The following is a description of a gene set: studied in species Homo sapiens Human Gene Set: DESERT_PERIPORTAL_HEPATOCELLULAR_CARCINOMA_SUBCLASS_UP Genes up-regulated in the periportal-type subclass of hepatocellular carcinomas. Sets created as part of a metaanalysis of nine public transcriptomic datasets merged into a metadataset including 1133 human hepatocellular carcinomas obtained after curative resection. For platform descriptions of each one of the 9 datasets, see Figure 1B in Désert et al., Hepatology (2017), 66: 1502-1518. Hepatocellular carcinomas (HCCs) exhibit a diversity of molecular phenotypes, raising major challenges in clinical management. HCCs detected by surveillance programs at an early stage are candidates for potentially curative therapies (local ablation, resection or transplantation). In the long term, transplantation provides the lowest recurrence rates. Treatment allocation is based on tumor number, size, vascular invasion, performance status, functional liver reserve and on the prediction of early (< 2 years) recurrence, which reflects the intrinsic aggressiveness of the tumor. Well-differentiated, potentially low-aggressiveness tumors form the heterogeneous molecular class of non-proliferative HCCs, characterized by an approximate 50% beta-catenin (CTNNB1) mutation rate. To define the clinical, pathological, molecular features and the outcome of non-proliferative HCCs, we constructed an 1133-HCC transcriptomic metadata set and validated findings in a publically available 210-HCC RNAseq set. We show that non-proliferative HCCs preserve the zonation program that distributes metabolic functions along the porto-central axis in normal liver. More precisely, we identified two well-differentiated, non-proliferation subclasses, namely Periportal-type (wild-type CTNNB1) and Perivenous-type (mutant CTNNB1), which expressed negatively correlated gene networks. The new Periportal-type subclass represented 29% of all HCCs; expressed an HNF4A-driven gene network, which was down-regulated in mouse Hnf4a-KO mice; were early-stage tumors by BCLC, CLIP and TNM staging systems; had no macrovascular invasion and showed the lowest metastasis-specific gene expression levels and TP53 mutation rates. Also, we identified an 8-gene Periportal-type HCC signature, which was independently associated with the highest 2-year recurrence-free survival by multivariate analyses in two independent cohorts of 247 and 210 patients. Conclusion: Well-differentiated HCCs display mutually exclusive periportal or perivenous zonation programs. Among all HCCs, Periportal-type tumors have the lowest intrinsic potential for early recurrence after curative resection. from publication Désert R, Rohart F, Canal F, Sicard M, Desille M, Renaud S, Turlin B, Bellaud P, Perret C, Clément B, Lê Cao KA, Musso O (PMID 28498607), and this is the list of marker genes: APOA1, RGN, ETNPPL, GLYAT, SRD5A2, ATRN, FBP1, ABAT, TENM1, KMO (kynurenine 3-monooxygenase), OGDHL, NDRG2, ACSM1, GBA3, TAT, CLDN15, ADH1A, GRAMD1C, NR1I3, GCDH, AZGP1 (NCBI Gene Id 90053), SLC10A1, MASP2, SLC22A1, GCH1, ECHDC2, LCAT, CYP4F2, MFAP3L, PLG, ACSL1, RDH16, CYP3A43, FXYD1, PPP2R1B, KDM8, VIPR1, HMGB3, CSTA, MLLT11, GPN3, RIDA, PON1, CYP2C18, ANO1, GPR88, HAL, GSTZ1, CYP7A1 (NCBI Gene Id 1581), ERO1B, ALDH2, ALDH8A1, BHMT, SLC1A1, GADD45A, SLC22A7, C8A, AKR7A3, CYP4A11, CYP2C9, HRG, C8B, TDO2, ARG1 (arginase 1), ECM1 (NCBI Gene Id 1893), LRRC31 (leucine rich repeat containing 31), PCK1, SLC46A3, NR1I2, EHHADH, CRY1, PBLD, ACADL (NCBI Gene Id 33), C9, ZGPAT, AFM (afamin), APOF, LPA, HPX, ACSM3, CYP2J2, ABCA6, ITIH4, FTCD, HAO1, G6PC1, ADRA1A, ABCA8, PCK2, LRRC20, IGFALS, GLS2, F9, ASPA, IGF1, KLKB1, AKR1D1, CTH, EPHX2, ANXA10, LGALS4, MNS1, SORL1, OTC, ACACB, C1R, HAO2, C6, ETFDH, SPP2, PEMT, CYFIP2, GNB5, GPD1, SLC37A4 (NCBI Gene Id 84965), SAA4, C7, FAH, KCNN2, PXMP4, CYP2B7P, NAT2, ABCB4, MAN1C1, ASS1, SOCS2, CD14, TCF7L1, DHRS1, RPF1, BDH2, ESR1 (NCBI Gene Id 2099), UPB1, DPYS, ANPEP, GYS2, SCGN, FAM149A, AGXT, SLCO1B1, GHR (NCBI Gene Id 2690), GSTA1 (NCBI Gene Id 2938), GNMT, GNE, CPEB3, SDS, FETUB, DNASE1L3, PRPS1, SLC27A5, CDA, CRHBP, GPR37, CPS1 (carbamoyl-phosphate synthase 1), FOLH1B, ALDOB, CBS, CYP2C8, HAMP